Given this list of marker genes ABHD8, TWF1, PFN2, CSNK1A1, GSN, TBCD, SPTB, TRAF3IP1, TRIM65, CAPG, SNCA, CAPZA3, SPTA1, ABHD17A (abhydrolase domain containing 17A, depalmitoylase), PRKCZ, SPTBN4, IAPP, LMOD1, DMTN, CARD8, TRIM31, HSPA8, BBS4, DNAJC15, SOX9, FLII, BCL11A, SLIT2, CRACD, PFN1, HIP1R, AKAIN1, RAF1, LMOD2, CRBN, RIOK3, SIRT2, STXBP1, LMO4, CARMIL1, LCMT1, PYDC5, KIF14, VPS35, ARFGEF1, EPS8, TMSB4X (NCBI Gene Id 7114), LAMP2 (NCBI Gene Id 3920), AIDA, PARK7, ADD3, SVIL, CPTP, PRKCD, TUBB4A, HDAC6, VILL, TMOD1 (NCBI Gene Id 7111), TMOD2, SPTBN1, HSPA5, FBXL2, AVIL, CTNNBIP1, TMC8, IFI16, ZNF827, HMGB1, SPTAN1, RDX, DYRK1A, CLIP3, SVIP, MYADM, TMOD3, KANK3 (NCBI Gene Id 256949, KN motif and ankyrin repeat domains 3), CRYAB, TWF2, CDC42, HSF1, CAPZA1, CAPZB, CDH5, TRIOBP, DDX3X, DACT1 (NCBI Gene Id 51339), JMJD6, KANK4, SSH3, PYDC2, ISL1, SPTBN2, MAPRE1, NLRP2B, EP300, GBA1, NOP53, CFL1, SRC, MIR17, SSH2, ULK1, MTPN, OGT, MEFV, SPTBN5, CAPZA2, ADD2, TFIP11, KANK1, FKBP4, INPP5J, TRIM11, EML2, ASB2, GSK3B, MIR214, ANKRD27, NLRC3, IRGM, PTGER4, PYDC1, CLU, CYRIB, WASHC2C, BIRC2, TMOD4, KANK2, SCIN, STMN1, MAP2, SOST, ARHGEF7, ZDHHC12, SSH1, LMOD3, MKKS, TREM2, RPL13A, DKK1, PEX5, PRRT2, SORL1, STMN2, THRA, OPRD1, CARMIL2, JAM3, ADD1, VIL1, here is a description of the gene set: Any process that stops, prevents, or reduces the frequency, rate or extent of protein complex assembly. studied in species Homo sapiens Human Gene Set: GOBP_NEGATIVE_REGULATION_OF_PROTEIN_CONTAINING_COMPLEX_ASSEMBLY